The following is a description of a gene set: Genes down-regulated in bone marrow-derived macrophages: untreated versus stimulated by interferon alpha. Human Gene Set: GSE35825_UNTREATED_VS_IFNA_STIM_MACROPHAGE_DN studied in species Homo sapiens We used microarrays to compare interferon-alpha (IFNa)- and interferon-gamma (IFNg)-stimulated genes under an equivalent biological input. The goal was to compare IFNa- and IFNg-stimulated genes, as well as to identify common and distinct sets of type I and II ISGs. from publication Liu SY, Sanchez DJ, Aliyari R, Lu S, Cheng G (PMID 22371602), and this is the list of marker genes: SETDB2, IFIT3, NFKBIZ, BRD2, TGM2, GYPC, HIF1A, CD69, SPINT2, SRGN, MDFIC, CHIC1, MIER3, SP110, PLAGL2, GTF2F1, INSM2, LYN, ATP9A, LRRC4 (NCBI Gene Id 85321), PCGF5, CMPK2, NUDT13, NDEL1, ENPP4, PPP1R15B, ISG15, RGS14, CRYBG1, MRPL52, MIR503, SOD2, DDC, GLIS1, ALDH1B1, TREX1, TRAF1, MYCL, TNFAIP3 (NCBI Gene Id 7128), SIPA1L1 (signal induced proliferation associated 1 like 1), PARP12, NFKBIE, CD47, SPSB1, SAV1, IL18BP (NCBI Gene Id 10068), TNFAIP6, SERPINE1, STOML1, ZNFX1, SNX10, SLC30A4, HIVEP2, IRGM, ZC3H12A, JAK2 (NCBI Gene Id 3717), MAFK, SNW1, HIVEP3, TNFRSF12A, CXCL11, GBP4, GCNT2, KDR, SLC23A2, SAMHD1, TPST1, USP18, GCH1, ATP10A, F11R, ADAD1, SBDS, ITGA5, DNASE1L3, NFKBIB, PAFAH1B2, AIM2, CRYBB3, TBC1D13, IFI35, MIR455, PPP1R10, KRTAP7-1, TAP1, MBD1, PARP11, NFKB2, IFI16, RRBP1, SEC23B, CHODL, FLNB, MED7, SPRED1, SOCS1, ATOH1, FZD5, DTX2, GGCT, DBNL, OLR1, MRPL39 (mitochondrial ribosomal protein L39), IRF1, KLK9, SLCO3A1, ZC3H12C, TM4SF1, PFKFB3, FAM53C, PROCR, IL36G, TNFSF15, SAMSN1, SEMA4C, ZFAND5, LZTFL1, MYL1, ATF3, RMDN3, ZBTB7A, NOD2, TNFSF8, TMEM232, CALML3, FCGR1A, ANKS4B, P4HA1, SNX18, RABGEF1, GNA13, DAXX, PGA5, WSB2, AP3B1, DTWD1, FAS, ROBO2, STXBP1 (NCBI Gene Id 6812), PIK3R5, IL27, ATP9B, ITPKB, BCO2, HCN2, LIPG, NAB1, SH3BP4, ACVR1, IL6, IL1RN, PRKRIP1, RNF19B, CEMIP2, ADORA2B (adenosine A2b receptor), EDN1, DISP3, SLC25A22 (NCBI Gene Id 79751), XAF1, CFLAR, VPS37B, NMI, TRIOBP, TIMP1, NECTIN4, MALT1, TRMT61B, BATF2, NGF